Given this list of marker genes CIDEB, CIDEA, CLSTN3, CIDEC, PNPLA2, LDAH, here is a description of the gene set: Human Gene Set: GOBP_LIPID_DROPLET_FUSION The process by which a single lipid droplet is created from the fusion of two or more lipid droplets. species: Homo sapiens